The following is a description of a gene set: studied in species Homo sapiens Human Gene Set: GOBP_FATTY_ACID_METABOLIC_PROCESS The chemical reactions and pathways involving fatty acids, aliphatic monocarboxylic acids liberated from naturally occurring fats and oils by hydrolysis., and this is the list of marker genes: FADS2B, ACOT4, CYP2A7 (NCBI Gene Id 1549), MGLL, AACS, ABHD1, PRKAG3, HADH, LPGAT1, ECHDC3, NAAA, ACOT6, GPX1, LYPLA1, ACSM6, ACSF2, ACSM2A, GPAM, BAAT, AUH, ADIPOR2, MIR132, GHSR, MID1IP1, AKR1C3, FADS2, ACAD11, KAT2B, LPL, SLC22A13, ACADSB, FADS3, PLA2G4D, IL1B, GSTM4, ELOVL3, SCD, PLA2G1B, UBR4, PEX5, AIG1 (androgen induced 1), APOC1, MECR, CES2, LPIN1, INSIG1, PTGES3, APOA5, AKT1, HACD1, ERFE, ADIPOR1, SREBF1, SLC45A3, CYP2A13, ADTRP, XBP1, CYP2A6, ABHD6, THEM5, PDK3, UGT1A9, FABP5, APPL2, CTHRC1, QKI, PNLIPRP1, ALOX15B, ELOVL7, ALOX15, ERLIN2, CYP3A4, LYPLA2, SLC27A6, DGAT2, HADHB, PPARGC1A, UGT1A8, GDF15, PTGR1, CYP2C9, IRS2, ACOT11, LIPA, PTGDS, CYP2B6, PLAA, ACSL1, IRS1, AKR1C2, ETFB, SLC27A3, PLA2G5, CROT, ALDH1L2 (aldehyde dehydrogenase 1 family member L2), MLYCD, GSTM1, PCK1, ABHD3, TYSND1, ACBD5, ECI1, GSTP1, DECR1, GLYATL2, NFE2L1, MIR185, GGT5, CYP4V2, MIR30C1, PRKAB2, PRKAA2, ACLY, SLC27A2, PRKAB1, ACSS2, SLC25A17, FABP2, SIRT2, EHHADH, EDN1, FMO4, HPGD, PNLIPRP2, CYP4A11, APOA4, HAO1, ACADL, AOAH, CYP4B1, HSD17B8, SLC27A1, NCOR1, MAPK14, ACACB, AMACR, ECHDC1, DBI, UCP3, SOX9, KLHL25, SCAP, UGT1A3, LIAS, CES1, MCEE, HTD2, ATP6V1B1, PEX13, HACD2, NR1H2, MIR204, MIR548P, ACAA1, PNLIPRP3 (pancreatic lipase related protein 3), CPT2, CYP7A1, GIP, INSIG2, ALOX12B, ENSG00000293349, CYP2C8, CYP4F12, FMO1, HADHA, MTLN, LONP2, ACSL6, TMEM135, SIRT1, HPGDS, TREX1, CYP4F3, ADIPOQ (adiponectin, C1Q and collagen domain containing), HACL1, ACSL4, AKT2, NUDT19, ABCB11, CYP4A22, PHYH, APOC2, PTGES, ECI2, PNLIP, MCAT, ERLIN1, MFSD2A, ADH7, CYP4F8 (NCBI Gene Id 11283), GCDH, LTC4S, HSD17B12, DCAF5, PCCB, SCD5, EPHX1, PEDS1, GSTA1, ACSBG1, CPT1B (carnitine palmitoyltransferase 1B), ELOVL1, SLC27A4, ANGPTL4, PTGS2, ALDH3A2, ACADVL, HACD4, ACAD9, ABHD2, NDUFAB1, DAGLB, PRKAG1 (protein kinase AMP-activated non-catalytic subunit gamma 1), ACOXL, TNXB, SNCA, PLA2G3, HSD17B10, ELOVL2, CD74, CYP4Z1, BRCA1, POR, ACOT9, ASAH1, ACBD4, PANK2, ACOT8, CYP1A1, ECH1, ABHD5, IVD, MIF, CYP2C19, ACOX1, HAO2, PLA2G4F, OXSM, TECRL, ACAT2, ACACA, AVP, SGPL1, ABCD3, PLP1, PTGR2, ABCC9, NUDT8, HSD17B4, UGT1A4, THNSL2 (threonine synthase like 2), MORC2, MSMO1, SIRT4, HACD3, ACSS1, ABCD4, UGT1A10, ABCD1, PLA2G15, PEX2, TWIST1, PDK2, CEACAM1, ANGPTL3, PLA2G2F, TBXAS1, CYP1B1, ACAD10, GGT1, MLXIPL, DECR2, PRKAA1, PCK2, ACSM2B, PTGES2, MBLAC2, PER2, INS, TYRP1, ACOT1, EDN2, PLA2G10, ACSM3, ACOT2, PDK1, ACSF3, ELOVL5, PGK1, CBR1, LPIN2, ACOX3, ACOX2, CAV1, CYP2J2, PTGS1, ASAH2, PPARA, AVPR1A, FAAH2, PM20D1, CPT1C, TNFRSF1A, ACAA2, GPAT4, DAGLA, UGT1A1, CYGB, PLA2G4C, ALKBH7, PLA2G4A, ETFA, EIF6, APOC3, CBR4, ETFBKMT (electron transfer flavoprotein subunit beta lysine methyltransferase), OLAH, ANKRD23, TPK1, FA2H, ECHS1, CRAT, CRYL1, CYP4F11, SCP2, CYP2C18, ALOX5, ACSL3, ACSM5, ADH4, PRKAG2, PPARD, CYP2S1, PLIN5, CYP2U1, ACSM1, PIBF1, PECR, ALOX12, MIR342, CPT1A, TECR, PEX7, ECHDC2, ETFDH, ACBD7, CYP2D6, CD36, MIR96, NDUFS6, BDH2, THEM4, AKR1C1, MIR33A, PNPLA3, PRKAR2B, PTGIS, FASN, C3, LIPG, SLC27A5, AWAT1, GPX4, PDK4, CYP2E1, ABCD2, LEP, GSTM2, MIR182, MIR766, TRIB3, ACADM, CYP1A2, UGT1A6, ELOVL6, AKR1B1, FADS1, COMT, ACSM4, AKR1C4, CYP2F1, MGST3, ILVBL, LIPC, GPIHBP1, UGT1A7, MMUT, ACAT1, ALOXE3, ACADS, FAAH, PPARG, FADS6, PRXL2B, CYP4F2, PCCA, LPIN3, AASDH, FABP3, ACSBG2, ACOT7, WDTC1, FMO2, PLA2G4B, ELOVL4, NR1H3 (nuclear receptor subfamily 1 group H member 3), BCKDK, ACSL5, ADH5, SESN2 (sestrin 2), PNPLA8, ABHD12, ACOT12, DEGS1, NUDT7